The following is a description of a gene set: Reactome Pathway: Reuptake of GABA part of: GABA synthesis, release, reuptake and degradation This event has been computationally inferred from an event that has been demonstrated in another species.<p>The inference is based on the homology mapping from PANTHER. Briefly, reactions for which all involved PhysicalEntities (in input, output and catalyst) have a mapped orthologue/paralogue (for complexes at least 75% of components must have a mapping) are inferred to the other species. electronically inferred by orthology from the curated human pathway studied in species Mus musculus, and this is the list of marker genes: Slc6a1, Slc6a13